Given this list of marker genes A1cf, Hnrnpab, Rbm47, Apobec1, Syncrip, here is a description of the gene set: studied in species Mus musculus A protein complex that posttranscriptionally catalyzes insertion, deletion or substitution of nucleotides at multiple sites within nascent mRNA transcripts to produce mature mRNAs in eukaryotes. Mouse Gene Set: GOCC_MRNA_EDITING_COMPLEX